Given this list of marker genes Ccna2, Ywhah, Ywhaq, Sfn, Ywhaz, Ywhab, Cdc25c, Ywhag, Cdk1, Ccnb1, Chek2, Ywhae (NCBI Gene Id 22627), Wee1, Ccna1, here is a description of the gene set: Chk1/Chk2(Cds1) mediated inactivation of Cyclin B:Cdk1 complex Mouse Gene Set: REACTOME_CHK1_CHK2_CDS1_MEDIATED_INACTIVATION_OF_CYCLIN_B_CDK1_COMPLEX studied in species Mus musculus